The following is a description of a gene set: Reactome Pathway: Glycogen storage disease type Ia (G6PC) part of: Glycogen storage diseases studied in species Homo sapiens Glucose-6-phosphatase (G6PC) associated with the inner face of the endoplasmic reticulum membrane normally catalyzes the hydrolysis of glucose-6-phosphate to glucose and orthophosphate. Defects in glucose-6-phosphatase are the cause of glycogen storage disease type Ia., and this is the list of marker genes: G6PC1